The following is a description of a gene set: Pathway Definition from KEGG: OA+AcCoA -- (CS,ACLY) >> ACO1/2 >> IDH -> 2OG Human Gene Set: KEGG_MEDICUS_REFERENCE_CITRATE_CYCLE_FIRST_CARBON_OXIDATION Citrate cycle, first carbon oxidation. Pathway ID: N01604. Pathway type: Reference. Pathway class: nt06031 Citrate cycle and pyruvate metabolism. species: Homo sapiens, and this is the list of marker genes: IDH2, ACO1, CS, IDH3G, IDH1, ACO2, ACLY, IDH3B, IDH3A